Given this list of marker genes TUBA8, GABBR2, PPP1R21, PLCB3, IFT56, RAB3GAP2, SEPSECS, POU1F1, MPDU1 (NCBI Gene Id 9526), TBCK, FIG4 (FIG4 phosphoinositide 5-phosphatase), RTTN, GLUL, ZNF335, DPYD, PEX26, GPHN, KIF15, TUBB3, LAMB1, WDR62, MED25, NTNG1, YY1 (YY1 transcription factor), CASK, CYB5R3, SLC25A19, CLTCL1, MT-TL1, ABCC6, SMC1A, NR4A2, PIGS, RNASEH2A, POLRMT, INSR, CACNA1I, UGDH, TAF8, CHKA, PIGN, DLK1, DEGS1 (delta 4-desaturase, sphingolipid 1), MT-ATP6, ALG2, PRIM1 (NCBI Gene Id 5557), ARX, MTR, SLC33A1, UGP2, KCNC2, GNPTAB, TBL1XR1, MN1, PEX12, TBC1D2B, FGF13, DENND5A, PRORP, PHGDH, DEPDC5, SATB2, ERCC2, MAB21L1 (mab-21 like 1), GTPBP2, NDUFA8, MEIS2, RPS6KA3, FBXL4, VPS4A, DALRD3, POMK, ALG1, JAG1, SLC25A46, EMG1, PSMC3, ACTL6B (actin like 6B), GAMT, NEXMIF, TSEN54, PEX11B, PEX2, NAA10, ACO2, CDKL5, GLYCTK, RTL1, MT-ND4 (mitochondrially encoded NADH:ubiquinone oxidoreductase core subunit 4), VPS53, SNIP1, PEX6, TRIM8, MGAT2, SLC16A2, TSEN15, TBR1, MAPKAPK5, KCNJ6, ADK, TRAPPC2L, ST3GAL3, DAG1, MADD, SLC9A6, NIN, MT-ND5, MRAP, VPS51, GEMIN4, ACOX1, RBL2, GSX2, ESAM, KATNB1, OTX2, COPB2, ADAR, SCN2A, ERCC6, GLI2, RNU4-2, PEX19, PEX5, TUBB2A, POMGNT1, DYM (NCBI Gene Id 54808), RNASEH2C, LSM11, PEX10, PIGU, EXTL3, ERCC1, ATPAF2, DYRK1A, PURA, CTNND2, CTNNA2, EIF4A2, PIGW, STXBP1, ASNS, TRAPPC12, GRM7, COG8, TSEN34, MECP2, TELO2, SUCLA2, ECHS1, MT-TW, ARNT2, FUT8, ADNP, RELN, RNASET2, GRM1, PROP1, NDE1 (NCBI Gene Id 95348), RNF2, FGFR3, PEX14, RALGAPA1, FOXA2, PRMT7 (protein arginine methyltransferase 7), EXOC2, TXN2, KCNH1, PYCR2, DPM1, GRIN1, MT-ND6, H4C5, PEX13, ALG12, PEX3, SPTBN4, SNX14, ZPR1, UNC80, LHX4, BUB1B, PIGG, VPS35L, FOXP2, FTO, WDR26, INTS11, MEG3, GABRG2, DPYSL5, DYNC1I2, MT-TV, VPS11, EIF2S3, MT-TT, ENPP1, VPS50, TSEN2 (NCBI Gene Id 80756), ERCC5, MTRR, STRADA, AP3D1, MT-ND2, C18orf32, ADSL, CCDC47, HESX1 (HESX homeobox 1), PHACTR1, DOCK6, PEX16, SEMA5A, STAMBP, GABRA2, CYB5A, MT-ND1, TANGO2, NTRK2 (neurotrophic receptor tyrosine kinase 2), MT-ND3, ASXL3, DNM1, NKX6-2, SLC30A9, KDM5B, DEAF1, KARS1, KMT2B, MT-TK, INTS1, FZR1, SYT1, PEX1, GFM2, EXOC8, here is a description of the gene set: A severe delay in the achievement of motor or mental milestones in the domains of development of a child. Severe global developmental delay Human Gene Set: HP_SEVERE_GLOBAL_DEVELOPMENTAL_DELAY studied in species Homo sapiens